Given this list of marker genes SLC1A1, SLC7A9, SLC25A13 (solute carrier family 25 member 13), SLC1A4, SLC43A2, SLC1A2, MFSD12, SLC7A11, SLC3A1, SLC25A12, CTNS, here is a description of the gene set: Human Gene Set: GOMF_SULFUR_AMINO_ACID_TRANSMEMBRANE_TRANSPORTER_ACTIVITY studied in species Homo sapiens Enables the transfer of sulfur amino acids from one side of a membrane to the other. Sulphur amino acids contain sulfur in the form of cystine, methionine or their derivatives.